Given this list of marker genes Src, Plaa, Arl1, Ccl8, Pdgfra, Arf1, Hras, Arf4, Arhgap6, Btk, Casp3, Apoc2l, Gm2a, Fyn, Apoc2, Stx4a, Ccl5, Ccl3, Pdpk1, Eed, Lck, Nsmaf, here is a description of the gene set: studied in species Mus musculus Binds to and increases the activity of a phospholipase, an enzyme that catalyzes of the hydrolysis of a glycerophospholipid. Mouse Gene Set: GOMF_PHOSPHOLIPASE_ACTIVATOR_ACTIVITY